The following is a description of a gene set: Genes in the cancer module 486. Human Gene Set: MODULE_486 studied in species Homo sapiens, and this is the list of marker genes: ARHGAP23, RARA, CYP3A7, CHKB, TAF6, ALPK2 (alpha kinase 2), PRKCQ, EDARADD, HDAC7, CRYAA, KIF1A, CTF1, VNN1, CCNT1, HOXA10, CAMKV, EN2, SLC19A1, SLC35F6, INTS1, CDC6, PRPF8, CCNL2, LRRC37A4P, AMT, RNPC3, SF3B1, VPS72 (vacuolar protein sorting 72 homolog), MYO9A (NCBI Gene Id 80251), DBH-AS1, PEX5, GNAZ, SNRNP70, ASS1, LUC7L3, CROCCP2, ADM, APBA1, USHBP1, SNPH, BACE2, APLP1, DDX17, DNAJC4, RNF40, PLXNB1, RALGAPA2, ARGLU1, RAB11B, RBM6, TBCK, TSC2, RALGAPA1P1, CLUHP3 (clustered mitochondria homolog pseudogene 3), INPPL1, UGT2B7, SPPL2B, CD14, ENG, SHBG, SCD, OGDHL, MAP4K2, TRAF2, ATG16L2, CCND2, MPRIP, MAOB, GSTM2, SULT1A3, IGFBP2, VDR, PARD6B, MED12, SLC35A4, IGSF1, PNPLA2, REEP1 (receptor accessory protein 1), HDAC10, PLXND1, TFR2, DEDD, GPRASP1, SERPINB6, BCAS1, BDKRB2, PWWP3A, JAG2, TRPM2, FKBP8, DDX5, STARD10, ATAT1, CKB, CCNF, CABYR, NHERF2, KMT2D, STMN1, IFT43